The following is a description of a gene set: species: Homo sapiens The chemical reactions and pathways involving tRNA, transfer RNA, a class of relatively small RNA molecules responsible for mediating the insertion of amino acids into the sequence of nascent polypeptide chains during protein synthesis. Transfer RNA is characterized by the presence of many unusual minor bases, the function of which has not been completely established. Human Gene Set: GOBP_TRNA_METABOLIC_PROCESS, and this is the list of marker genes: EXOSC10, MARS1, VARS1, FAM98A, POP7, RTRAF, WDR6, DTWD1, TRNT1, SEPSECS, EPRS1, TYW3, TARBP1 (NCBI Gene Id 6894), FARSA, TARS1, DARS1 (NCBI Gene Id 1615), THG1L, DTWD2, GTPBP3, YARS2, ADAT3, GTF3C3, GATB, ELP5, C2orf49, POLR2F, AARSD1, NSUN6, QTRT1, ELP1, TSEN34, PRORSD1P, THUMPD2, TRMT6, QNG1, TPRKB (NCBI Gene Id 51002), TRMT12, METTL2A, POLR3A, EXOSC8, GTF3C4, TSEN54, TRMT44, TARS2, LCMT2, METTL6, DALRD3, CDK5RAP1, PRORP, FAM98B (family with sequence similarity 98 member B), TYW1B, CTAG2, DUS4L, GTF3C1, DARS2, EXOSC2, TRMT5, TSEN15 (NCBI Gene Id 92120), ELP6, MTFMT, RPP25L (NCBI Gene Id 138716), LARS2, IARS2, TRDMT1, TARS3, AARS2, MOCS3, HARS1, ZCCHC7, AARS1, THUMPD3, DUS3L, GTF3C6, CTAG1A, RPUSD4, NSUN3 (NOP2/Sun RNA methyltransferase 3), LSM6, METTL8, ANG, TRMT61B, GATC, SLFN13, TYW5, IARS1, TRMT10A, GON7, GRSF1, RPP40, FTSJ1, POLR2E, PUSL1, ELP2, LRRC47, DDX1, TYW1, RARS1, DPH3 (diphthamide biosynthesis 3), SSB, RPP21, RPP30, DUS2, RNH1, OSGEPL1 (O-sialoglycoprotein endopeptidase like 1), GARS1 (glycyl-tRNA synthetase 1), FARSB, TRMU (tRNA mitochondrial 2-thiouridylase), TRMT1, DUS1L, TRMT11, FARS2, EXOSC9, EARS2, NARS2, TP53RK, QRSL1, CARS2, RPP38, DICER1 (NCBI Gene Id 4333), TRMT2B, SARS2, ANKRD16, TRMO, QTRT2, NSUN2, ELP3, PUS7, NARS1, SARS1, TRIT1, MARS2, WARS2, TRMT1L, PUS3, HSD17B10, THUMPD1, KARS1, POP4, RPPH1, TSEN2, LAGE3, TRMT10C, POP5, TRUB1, METTL2B, WDR4, ADAT2, TRMT61A, THADA, AKT1, ZBTB8OS, GTF3C2, NAT10, VARS2, URM1, EXOSC7, POP1, PUS10, GTDC1, HARS2, YARS1, ALKBH1, TRUB2, RTCB, TRMT10B, CARS1, POLR3D, GTF3C5, METTL1, TRMT13, ALKBH8, QARS1, ELAC1, YRDC, DTD1, BCDIN3D, PTCD1, CTAG1B, KTI12, TRPT1 (NCBI Gene Id 93089), RPP14, LARS1, EXOSC3, B3GNTL1, CDKAL1, CTU2, RPP25, ELAC2 (elaC ribonuclease Z 2), TRMT112, CTU1, CLP1 (cleavage factor polyribonucleotide kinase subunit 1), BRF1, WARS1, TRMT9B, MTO1, OSGEP, DTD2, TRMT2A, ELP4, PARS2, POLR2L, ADAT1, PUS1, RARS2